The following is a description of a gene set: Enables the transfer of a solute or solutes from one side of a membrane to the other according to the reaction: solute(in) + HCO3-(out) = solute(out) + HCO3-(in). Mouse Gene Set: GOMF_BICARBONATE_MONOATOMIC_ANION_ANTIPORTER_ACTIVITY species: Mus musculus, and this is the list of marker genes: Slc4a1, Slc26a6, Slc26a9, Slc26a7, Slc4a3, Slc26a4, Slc4a9, Slc4a2, Slc26a3, Slc4a10 (NCBI Gene Id 94229), Slc26a5, Slc4a8, Slc26a11